The following is a description of a gene set: Childhood acute lymphoblastic leukemia (ALL) is curable with chemotherapy in approximately 80 percent of patients. However, the cause of treatment failure in the remaining 20 percent of patients is largely unknown. Genes distinguishing prednisolone resistant and sensitive ALL (B- and T-lineage ALL); here - genes down-regulated in the drug resistant samples. from publication Holleman A, Cheok MH, den Boer ML, Yang W, Veerman AJ, Kazemier KM, Pei D, Cheng C, Pui CH, Relling MV, Janka-Schaub GE, Pieters R, Evans WE (PMID 15295046) Human Gene Set: HOLLEMAN_PREDNISOLONE_RESISTANCE_ALL_DN studied in species Homo sapiens, and this is the list of marker genes: SLC11A1, KIR3DL2, CST7, MATK, DAPK1, MATN1, ARPC2, PIEZO1, POLH, CA4, STOM